Given this list of marker genes SNX18, SFXN1, GAN, RAB39B, CRLS1, KITLG, ZNF527, KLHL14, ETNK1, ASTN2, DCLK1, ASAP2, WBP11, CDK9, CCDC82, SNTG1, FYB2, MDGA2, C14orf28, SFTA3, MTHFD2, RGS7, TIMM22, HNRNPD, ONECUT2, PRPF38A, PXDN, SLCO1A2, KLHL11, GNL1, PPM1D, R3HDM1, AZIN1, TENT5A, LCORL, PIM3, FMR1, DAZAP2, LIN7A (NCBI Gene Id 8825), ELL2, ZNF768, RNF139, ANTXR2, FUT8, PCTP, ACVR1, PSME4, RASSF6, MMACHC, SRSF10, STYX, SRSF2, SESTD1, MIER1, AGXT2, COLGALT2, SLC6A15, KCNA4, UNC80, GPAT2, SERTAD2, PIGH, NECAP1, DEFA5, CSGALNACT1, AKR1E2, ATP8A1, GATAD2B, FNIP2, KCNMB4, UNC13C, TARDBP, PYROXD1, SGK3, NRG3, SRP72, NCAN, CD164, EPHA7, CRAMP1, ARG2, RAB39A, MBNL2, C8orf44-SGK3, FBXL17, MRPS5, OXSR1, KIF2A, UBA6, PLA2G4A, ATXN2L, MIER3, FABP5, BACH2, here is a description of the gene set: Human Gene Set: MIR203B_3P Genes predicted to be targets of miRBase v22 microRNA hsa-miR-203b-3p in miRDB v6.0 with MirTarget v4 prediction scores > 80 (high confidence targets). from publication Chen Y, Wang X (PMID 31504780) studied in species Homo sapiens